Given this list of marker genes Foxp1, Evx1, Sox6, Ercc2, Lbx1, Med12, Neurog3, Mnx1, Nkx6-2, Tctn1, Ift80, Gsx2, Gbx1, Hoxb8, Mecp2, Ighmbp2, Drgx, Lhx1 (NCBI Gene Id 16869), Smo, Nkx2-2, Lhx5, Tal1, Uncx, Dbx1, Bag3, Pax7, Daam2, Abt1, Zpr1 (ZPR1 zinc finger), Gigyf2, Ift122, Gata2, Mir20a, Dll4, Gdnf, Lhx4, Loxl3, Pax3, Nkx6-1, Notch1, Nfe2l1, Sufu, Lrp8, Sox13, Wnt1, Wnt3a, Nog, Rfx4, Nf1, Pax6, Gdpd5, Sox4, Gria1, Lmo4, Plxdc1, Scyl3, Phox2a, Zic1, Suz12, Dab1, Mir19a, Sox11, Nfix, Cln8 (NCBI Gene Id 26889), Lhx3, Ptch1, Ift172, Gli3, Dicer1, Sox12, Vldlr, Rab23, Dync2h1, Foxb1, Tulp3, Mir17, Dctn1, Draxin, Akt1, Ift88, Ptprs, Gdf11, Intu, Isl1, Mtor, Lhx1os, Isl2, Vstm5, Mpst, Enpp1, Mir19b-1 (microRNA 19b-1), Olig2, Gsx1 (NCBI Gene Id 14842), Dcc, Pkd1, Tbx20, Slit1, Mir18, Gdf7, Reln, Shh, Actl6a, Dll1, Mir92-1, Sox1, Dmrt3, Foxn4, Chrd, Pkd2, Zc4h2, Adarb1, Gli2, Lonrf2, Nefl, Vit, Hoxc10, Olig3, Ascl1, Hoxd10, Phgdh, Scyl1, Pbx3, Cacna1a, Fuz (NCBI Gene Id 70300), here is a description of the gene set: The process whose specific outcome is the progression of the spinal cord over time, from its formation to the mature structure. The spinal cord primarily conducts sensory and motor nerve impulses between the brain and the peripheral nervous tissues. Mouse Gene Set: GOBP_SPINAL_CORD_DEVELOPMENT species: Mus musculus